Given this list of marker genes TRIB1, ACOT9, RAPGEF2, MTUS1, KCNE4, RUBCN, TRIM38, METTL25B, CPT1B, CCNL1, PIK3IP1, CLCN3, PHYH, LRRC2, GEM (NCBI Gene Id 2669), NKX2-1, HERPUD1, GOSR1, PPP1R10, POLB, H2AC18, CHMP4A, PLPP3, RBM4, CYTIP, IFITM3, TBC1D3F, C6orf120, C2orf42, BCL2L11, PDE8A, P2RX1, TSC22D3, N4BP2L2, TOMM34, ZNF215, SC5D, DENND3, ZNF571, HBEGF, H2AC10P, RNF114, HDGFL3, H3-3B, MRPL49, IFITM1, MBIP, SRSF5, SLCO4A1, STBD1, TUT7, CLDND1, AVPI1, F2R, IDI1, LCK, ICAM1, GIPR (gastric inhibitory polypeptide receptor), IRF7, COL1A1, SMN1, TTC17 (tetratricopeptide repeat domain 17), UBE2H, TGDS, RPS6KA2, GARRE1, SPTBN4, UBE2B, RGS13, MAP3K14, ARF4, NCOR2, RYBP, NRBF2, MAFF, PFDN2, MIR22HG, ARF6, TRAPPC2, TENT5A, ANKRD13C-DT, KANSL2 (KAT8 regulatory NSL complex subunit 2), WDR26, TJAP1, DUSP1, WSB1, NEK1, KDM6B, NAT9, JMJD6, TMSB4Y, TSPYL1 (TSPY like 1), EXT1, HLA-E, MBTPS1, C3orf52, THEMIS2, UFSP2, RPGRIP1L, PIGA, PRKRIP1, NUAK2, CCR2, CTSS, AREG, OSER1, DRD3, ATP1B3, SQSTM1, SLC35A2, PRPF4, MAP3K13, FRAT1, ATP6V0E1, FAM13A, YJU2B (YJU2 splicing factor homolog B), BEX4, POFUT2, ADPRM, GNAS, RGS2, NXF1, CLK1, APC2, TOB2, ARC, NLRP1 (NCBI Gene Id 82286), CTH, AZGP1, ABCG1, NR1D1, ID3, NGRN, MIS12, EOLA1, SIK3, DXO, GADD45B, PDGFB, HBP1, C3AR1, ODR4, SEC23B, ORC5 (NCBI Gene Id 5001), BDNF (brain derived neurotrophic factor), RIOK3, PNRC1, TYW1, CLK3, AKAP8L, SCNN1A, MARCKS, NFKBIA, SRC, DUSP5, JUND, ARIH1, AKTIP, TESC, HLA-DRB6, DUSP6, NFE2L1, H2AC7, MOB4, JOSD1, SNRK, TP53TG1, OTUD4, IVD, SLC35F5, CBX8, H3C4, GADD45A, ABCA8, FAM53C, PIP5K1B, CREM, ZNF222, MR1, OAS1, PFKFB3, RBMS1, PKP1, KLF4, PEX13, FEM1C, DUSP11, PLEKHM1, CD84, RHOB, FBXO34, GLIPR1, LDLRAD4, STX12, DENND4A, HAPSTR1, FOXD1, UNC50, IFRD1, H1-10, STX5, TK2 (thymidine kinase 2), DDX19A, CBS, CCN1, NMRK1, PLSCR1, TRMT1L, SEC62, NFU1, H2BC7, CIDEC, BTG3, KIN, CEBPB, PDE4A, INTS6, TNFSF10, MSRB2, PDE3B (NCBI Gene Id 5140), DNAJB6, RAB9A, RECQL5, H2AC13, ZNF34, PLIN2, ATAD2B, SLC3A2, ARG2, GALNT3, TUFT1, PPARGC1A, GTF2B (general transcription factor IIB), PGM3, DDX27, SDF2, BIN3, PEA15, SLCO4C1, SEC61A2 (NCBI Gene Id 88207), PMS2P8, H2BC12, ANKRA2, ATG12, NAP1L1, ALOX5AP, DUSP2, NFE2L2, TGS1, TACC2, DDX18, LY9, HCP5, JARID2, NECAP1, SAMSN1, GLA, DIP2C, KLF2, PPP2R5B, FBP2, IP6K2, TPBG, CDKN2AIP, GABARAPL1, CDC14A, HLA-DOA, CCNT2, PNLIPRP1, OFD1, DMTF1, C1orf50, BACH1, MCF2L, CASP9, IGF1, TMF1, SNHG32, STK17A, ARID4B, PPP1R3C, ISG20, SPRED2, EIF2AK3, STYXL1, MKRN1, SPATA2, NDEL1, TIMP1, HGSNAT, IRS2, EAF2, SUGCT, KSR1, MAPKAPK5-AS1, IRF1, CLK4, RSRC2, BASP1, NARF, SUSD6, KMO, PAK5, TERF2IP, SH2D2A, ST3GAL5, AP5Z1, CHTOP, ELK3, SLC25A13, DNAAF1, H2BC5, DGUOK, RUNX1, BCAS2, VDR, SP140L, KLF6, SKIL, SERINC3, ASCC1, SUPT6H, ZNF394, H4C3, DBNDD2, WHRN, USP36, ZNF274, PARP8 (NCBI Gene Id 79668), PDLIM3, IFIT1, TRIM33, DDX50, ZCCHC8, H4C12, ARMCX3, FNBP4, SIDT1, BET1, COMP, CXCR4, POLR1E, NAP1L2, ARID5B, TSTD2, TIGAR, CTSB, MTMR6, STAP1, BHLHE41, ZNF250, ID2, LIMA1, BCL3, FNBP1, TPM4, CHKA, GAD1 (glutamate decarboxylase 1), PPP1R15A, LAPTM4A, ZNF131 (zinc finger protein 131), ATP6V0A1, VAMP2, ETNK1, RNF11, MAP2K3, IFT57, AASS, GTPBP1, SFPQ, H2BC10, MAP4K3 (mitogen-activated protein kinase kinase kinase kinase 3), NR4A3, YES1 (NCBI Gene Id 7525), TAF1D, KDM3A, EZR, NAMPT, POPDC2, ACKR3, MYLIP, ZP3, CCL3, OASL, LDLR, CENPC, STK17B, POLR2A, USP20, LAX1, ETV1, THAP9-AS1, ZNF184, TLE3 (NCBI Gene Id 7090), ATG9A, PPP1R2, NEMF, SPOP, BBC3, STOM, JAK1, SCYL3, YY1AP1, ARMCX6, FOSL1, CCPG1, EGR4, AMPD1, RORA, BRD2, GMPR, CHST2, ZNF165, BRF2 (BRF2 RNA polymerase III transcription initiation factor subunit), TNFSF9, PTHLH, FOXO1, ARID3B, EIF1, ZNF140, SOCS1, ZBTB48, KDM7A, KLHL21, BSDC1, MCL1, HES1, RABGGTB, INS, SMAD3, SLC2A3, FOSB, TSPYL2, DIABLO, MORC3, IMPA1, NUDT9, MAP1LC3B, PHF1, TOR3A, ATF7IP, SORBS2, TRMO, CCNDBP1, DDIT3, here is a description of the gene set: from publication Mitsiades CS, Ocio EM, Pandiella A, Maiso P, Gajate C, Garayoa M, Vilanova D, Montero JC, Mitsiades N, McMullan CJ, Munshi NC, Hideshima T, Chauhan D, Aviles P, Otero G, Faircloth G, Mateos MV, Richardson PG, Mollinedo F, San-Miguel JF, Anderson KC (PMID 18593922) studied in species Homo sapiens Human Gene Set: MITSIADES_RESPONSE_TO_APLIDIN_UP Genes up-regulated in the MM1S cells (multiple myeloma) after treatment with aplidin, a marine-derived compound with potential anti-cancer properties. Despite recent progress in its treatment, multiple myeloma (MM) remains incurable, thus necessitating identification of novel anti-MM agents. We report that the marine-derived cyclodepsipeptide Aplidin exhibits, at clinically achievable concentrations, potent in vitro activity against primary MM tumor cells and a broad spectrum of human MM cell lines, including cells resistant to conventional (e.g., dexamethasone, alkylating agents, and anthracyclines) or novel (e.g., thalidomide and bortezomib) anti-MM agents. Aplidin is active against MM cells in the presence of proliferative/antiapoptotic cytokines or bone marrow stromal cells and has additive or synergistic effects with some of the established anti-MM agents. Mechanistically, a short in vitro exposure to Aplidin induces MM cell death, which involves activation of p38 and c-jun NH(2)-terminal kinase signaling, Fas/CD95 translocation to lipid rafts, and caspase activation. The anti-MM effect of Aplidin is associated with suppression of a constellation of proliferative/antiapoptotic genes (e.g., MYC, MYBL2, BUB1, MCM2, MCM4, MCM5, and survivin) and up-regulation of several potential regulators of apoptosis (including c-JUN, TRAIL, CASP9, and Smac). Aplidin exhibited in vivo anti-MM activity in a mouse xenograft model. The profile of the anti-MM activity of Aplidin in our preclinical models provided the framework for its clinical testing in MM, which has already provided favorable preliminary results.